The following is a description of a gene set: Human Gene Set: GOCC_U2_TYPE_SPLICEOSOMAL_COMPLEX Any spliceosomal complex that forms during the splicing of a messenger RNA primary transcript to excise an intron that has canonical consensus sequences near the 5' and 3' ends. species: Homo sapiens, and this is the list of marker genes: DDX46, LUC7L3, CDC5L, SNIP1, SF3A3 (NCBI Gene Id 10946), LUC7L, LSM3, SF3A1, LSM4, SART1, LUC7L2, SNRPN, PPIL1, PRPF8 (NCBI Gene Id 6108), SNRPA1, PRPF19, LSM2, SNRNP70, SNRPG, CWC27, SNRPD2, SF3B5, SRRM2, SMU1, RNF113B, IK, BUD13, SNW1, SNU13, ZMAT2, SF3B2, SNRPGP15, PLRG1, MFAP1, XAB2, SF3B6, CWC15, SNRPD3, HTATSF1, DHX15, RBM8A, TFIP11 (tuftelin interacting protein 11), SNRPB2, CCDC12, EIF4A3, CDC40, PRPF18, RNF113A, SF3B3, BUD31, SF3B4, PRPF4, PRPF40A, AQR, CRNKL1, DDX42, SNRPF, LSM6, PRPF39, ISY1, LSM8, DHX16, U2AF2, PRPF31, CWC25, SYF2, SNRPE, WBP4, PRPF6, EFTUD2, PPIE, PHF5A, DHX8, PRPF3, SNRNP40, YJU2, GCFC2, PRPF38A, LSM7, SNRNP200, CASC3, RBM22, TXNL4A, LSM5, SF3A2, SF3B1, MAGOHB, YJU2B, CWC22, PRPF40B, BCAS2, SNRPC (small nuclear ribonucleoprotein polypeptide C), SNRPD1, RBMX2, SNRPB (NCBI Gene Id 6628)